The following is a description of a gene set: Intrinsic Pathway of Fibrin Clot Formation studied in species Mus musculus Mouse Gene Set: REACTOME_INTRINSIC_PATHWAY_OF_FIBRIN_CLOT_FORMATION, and this is the list of marker genes: F8, Serpina5, F12, F9, Pros1, Proc, F2, Gp5, Klkb1, Kng2, Serpinc1, Vwf, F10 (coagulation factor X), Prcp, Gp1ba, Serping1, Gp1bb, Gp9, Serpine2, Serpind1, F11, A2m, C1qbp